The following is a description of a gene set: Human Gene Set: HP_EPIDIDYMAL_CYST Epididymal cyst A smooth, extratesticular, spherical cyst in the head of the epididymis. studied in species Homo sapiens, and this is the list of marker genes: CCND1, HNF1B, VHL, PIK3CA, SRCAP